Given this list of marker genes A630076J17Rik, Cp, Snx27, Cdkn2aip, Tchh, Cdon, Kcnv1 (potassium channel, subfamily V, member 1), Hnrnpu, Zbtb18, Erlin1, Hivep1, Eny2, Mapk8, Pigq, Loricrin, Insr, Stox2 (storkhead box 2), H2-T11-ps, Fnip1, Pgap1, Ccn4, Klf8 (NCBI Gene Id 245671), Ncoa2, Ccdc50, Ears2, Ppp3r1, Pcbp2, Gabrr2, Ptp4a1, Naa50, Ptpro, Slfn8, Cstf2, Tmed8, Mbnl1, Zswim6, Kras, Prom1, Slc37a4, A1cf, Rora, Nipsnap1, 4930426D05Rik, Mitd1, Snx12, Ppp1r3c, Decr1, Ubqln4, Eif3j1, Lce6a, Slbp, Csn3, Adgrl2, Lnpep, Gucy1a2, Ccdc138, Nup214, Pcdh15, Cdk17, Dusp22, Tle1, Cd28, Chmp3, Gjb5, Ube2d2a, Slc1a2, Oma1, Upp2, Cycs, Sypl2, Lcorl, Fgf13, Dst, Gm5938, Shisa2, Slc22a4, Septin11, Pon2, Cyp1b1, Calr4, Clcn3, Chd9, Pnma5, Akr1c14, Papolg, Tlk2, Ammecr1, Slc1a7, Eif3j2, Prkag2, Mrpl58, Cep162, Top1, Zfhx4 (NCBI Gene Id 80892), Serpinb6b, Sntg1, Tctn3, Rmnd5a, Arpp19, Ptgs1, Srek1, here is a description of the gene set: Genes predicted to be targets of miRBase v22 microRNA mmu_miR_3088_3p in miRDB v6.0 with MirTarget v4 prediction scores > 80 (high confidence targets). from publication Chen Y, Wang X (PMID 31504780) Mouse Gene Set: MIR_3088_3P studied in species Mus musculus